Given this list of marker genes FGB, FGG, F2, PLG, F13A1, F13B, FGA, here is a description of the gene set: studied in species Homo sapiens Human Gene Set: WP_COVID19_THROMBOSIS_AND_ANTICOAGULATION COVID-19, thrombosis and anticoagulation